Given this list of marker genes Cenpa, Klf2, Fos, Klf6, Fosb, here is a description of the gene set: Cytokines mediate cell-cell communication in the immune system and represent important therapeutic targets. A myriad of studies have highlighted their central role in immune function, yet we lack a global view of the cellular responses of each immune cell type to each cytokine. To address this gap, the authors created the Immune Dictionary, a compendium of single-cell transcriptomic profiles of more than 17 immune cell types in response to each of 86 cytokines (>1,400 cytokine-cell type combinations) in mouse lymph nodes in vivo. A cytokine-centric view of the dictionary revealed that most cytokines induce highly cell-type-specific responses. For example, the inflammatory cytokine interleukin-1β induces distinct gene programmes in almost every cell type. A cell-type-centric view of the dictionary identified more than 66 cytokine-driven cellular polarization states across immune cell types, including previously uncharacterized states such as an interleukin-18-induced polyfunctional natural killer cell state. from publication Cui A, Huang T, Li S, Ma A, Pérez JL, Sander C, Keskin DB, Wu CJ, Fraenkel E, Hacohen N (PMID 38057668) Mouse Gene Set: CUI_T_CELL_GD_IL17D_RESPONSE_DN Genes negatively differentially expressed in cell type: γδ T cell upon treatment with cytokine: IL-17D in mouse lymph nodes in vivo. species: Mus musculus